The following is a description of a gene set: The appearance of any member of the transforming growth factor-beta family of cytokines due to biosynthesis or secretion following a cellular stimulus, resulting in an increase in its intracellular or extracellular levels. Transforming growth factor-beta family members include TGF-B1, TGF-B2, and TGF-B3. Human Gene Set: GOBP_TRANSFORMING_GROWTH_FACTOR_BETA_PRODUCTION species: Homo sapiens, and this is the list of marker genes: LAPTM4B, GATA6, TGFB2, SERPINB7, CD24, SMAD3, LUM, LGALS9, CD200, IL13, CX3CL1, ATP6AP2, WNT11, CD46, MYB, THBS1, CD2AP, ITGB6, FERMT1, FN1, LILRB1, COL3A1, SMAD4, HIF1A, TSKU, SERPINF2, PTGS2, ITGAV, FURIN, BMPR1A, CREB1, FOXP3, ATF2, MIR149, XCL1, TYROBP, FBLN1